Given this list of marker genes Mknk2, Rnh1, Nsdhl, Adss1 (adenylosuccinate synthase 1), Hspa1a, Rasl11b (RAS-like, family 11, member B), Gpcpd1, Tgoln1, Vcan, Lpgat1, Bag3, Dynlt2a1, Hgsnat, Xdh, Pea15a, Eif1ax, Nr1d1, Fhl2, Echs1, Rrad, Elovl6, Glrx, Lcn2, Foxg1, U90926, Tgm3, Ifi205, Baiap2, Dcn, Hgf, Id3, Aldh3a1, Ifrd1, Serpini1, Fgf7, Cxcl5, Plat, Rdh11, Ddit3, Hspa1b, Klf4, Htatip2, Wwc1, Trib3, Slfn2, Acta2, Elmod3, Serpinb9f, Pim1, Id2, Lss, Cyb5r1, Slfn4, Ppp1r15a, Foxf2, Abhd5, Cxcl1, Postn, Tgtp1, Serpinb2, Clu, Dbp (NCBI Gene Id 13170), Dusp1, Nus1, Tmem45a, Kng1, Ereg, S100a8, Procr, Acsl1, Mafk, Hmgcr, Dnajb9, Lpl, Grem2, C3, Hmox1, Sh3gl3, Zfand2a, Mvd, Ngf, Prnp, Plaur, Ptx3, Rgs2 (regulator of G-protein signaling 2), Pparg, Orm1, Angptl4, Lyz2, Dnajb2, Ear1, Tom1l1, Serpinb9e (NCBI Gene Id 20710), Bckdhb, Atf3, H2bc4, Ear2, Junb, A530040E14Rik, Apbb1ip, Wfdc21, Sat1 (spermidine/spermine N1-acetyl transferase 1), Abcd2, S100a3, Cd1d1, Gml, Hbegf (NCBI Gene Id 225370), Igf2, Btg2, Abca1, Ssr1, H2ac18, Saa3, Ank3, Gla, Nxph2, Tfrc, Cd47, Hp, Gipc2, Ifi204, Cd68, Hsph1, Gsdme, Gadd45g, Hipk1, Per2 (period circadian clock 2), Usp17la, Dnajb1, Tnfaip6, Ier2 (immediate early response 2), Chordc1, Crabp2, H3c8, Xlr3a, Gch1, Caprin2, Gadd45b, Fos, here is a description of the gene set: CCAAT/enhancer-binding proteins (C/EBPs) are a family of transcription factors that regulate cell growth and differentiation in numerous cell types. To identify novel C/EBP-target genes, we performed transcriptional profiling using inducible NIH 3T3 cell lines expressing 1 of 4 members of the C/EBP family. Functional analysis revealed a previously unknown link between C/EBP proteins and circadian clock genes. Our microarray data showed that the expression levels of 2 core components of the circadian network, Per2 and Rev-Erbalpha, were significantly altered by C/EBPs. Recent studies suggested that Per2 behaves as a tumor suppressor gene in mice. Therefore, we focused our additional studies on Per2. We showed that Per2 expression is up-regulated by C/EBPalpha and C/EBPepsilon. Per2 levels were reduced in lymphoma cell lines and in acute myeloid leukemia (AML) patient samples. In addition, we generated stable K562 cells that expressed an inducible Per2 gene. Induction of Per2 expression resulted in growth inhibition, cell cycle arrest, apoptosis, and loss of clonogenic ability. These results suggest that Per2 is a downstream C/EBPalpha-target gene involved in AML, and its disruption might be involved in initiation and/or progression of AML. Mouse Gene Set: GERY_CEBP_TARGETS species: Mus musculus Genes changed in NIH 3T3 cells (embryonic fibroblast) by expression of one or more of C/EBP proteins: CEBPA, CEBPB, CEBPG, and CEBPD. from publication Gery S, Gombart AF, Yi WS, Koeffler C, Hofmann WK, Koeffler HP (PMID 15985538)